The following is a description of a gene set: species: Mus musculus Mouse Gene Set: GOBP_DEOXYRIBONUCLEOSIDE_METABOLIC_PROCESS The chemical reactions and pathways involving any one of a family of organic molecules consisting of a purine or pyrimidine base covalently bonded to a sugar deoxyribose (a deoxyribonucleoside)., and this is the list of marker genes: Dguok, Urah, Gda, Tk2, Tk1, Ada, Dera, Pnp, Uox, Dck, Dtymk, Urad, Xdh, Dpyd